Given this list of marker genes ANXA2, RHOU, PBRM1, AVL9, POLR2D, TESC, GLRX5, TMEM60, BUD23, VSNL1, TMEM200A, COL5A2, NEDD4L, DCAF4, SAMD9, ANKIB1, LYPD1, NXN, GPSM2, BHLHE41, MT1H, GSPT2, ATP5F1E, USP42, BOD1L1, TXNRD1, SUPT16H, PTPN21, MZT2B, NDUFB7, ABCB4, RPL6, MAML1, COQ5, WDR36, RGS17, NECTIN3, GATA2, MLLT3, FAM111A (FAM111 trypsin like peptidase A), CAVIN1, EEF1G, TNFAIP3, ACOXL, PNPT1, EHD3, PIN4, BAZ2B, TNFRSF9 (NCBI Gene Id 3604), BLVRA, PTCHD1, GMFB, SLC7A3, SPINK1, MARK3, VAMP1, LRRC75A, PLA2G3, PCDH20, BMP2, NCOR1, BAG5, TMEM87B, TTPAL, MYOF, NFE2L2, FGF13, BASP1, KRT34, RNF181, RIF1, PPP4R3A (protein phosphatase 4 regulatory subunit 3A), CYCS, PSMB3, ACVR1C, HNMT, CACNA2D2, BUB1, FUNDC2, MOAP1, ANXA2P3, TARS3, LRRN1, GHR, PRRX1, MC4R, MRPS24, IGF2BP3, ORMDL3, ABHD16B, FZD1, ANLN, ZFP62, EEF1B2, HEXIM1, COA3, TRIP12, CRK, ATP5F1A, PGR, VBP1, ZNF839 (NCBI Gene Id 55778), TPST1, MED6, FKBP14, DDX24, DHX8, CHCHD1, PIP5K1A, AAK1, SNX8 (sorting nexin 8), AGPS, VAMP7, NEK9, PAPSS2, SNAI2 (NCBI Gene Id 6591), MTERF1, PSME4, TMSB15B, LINC00460, FOXG1, HJURP (Holliday junction recognition protein), CDH7, MRPL44, TLE4, DUSP1, DDHD1, SRA1, APOBEC3B, UBE2C, SEPTIN7, CNOT6, RFC2, ACADL, LHFPL2, IFITM2, ELP5, DHRS2, PCDHB14, ZNF142, AMPH, TMEM200C, RACK1, FN1, UBE2QL1, GLI3, RALA, PAPOLA, CXCL8, COPS9, SSR4, AKR1C1, TSPAN7, MIS18BP1 (NCBI Gene Id 55320), NDUFA3 (NADH:ubiquinone oxidoreductase subunit A3), SAMD5, NRDE2, ADAMTS5, KCNK2, TOP1, ACTR10, SGO2, KIF18B, S1PR3, ZCCHC12 (NCBI Gene Id 257051), SLC27A6 (solute carrier family 27 member 6), ARPC2, ZNF544, CNRIP1, PSME2, PKP4, IFT57, TTLL4, BABAM1, GCC2, ZBED10P, UPP1, FSCN1, DNER, CA5BP1, ADAMTS1, YAE1, ID2, EDNRB, DBF4, NCAPH, CLASP1, TPPP (tubulin polymerization promoting protein), CCNB1, EGFLAM, SRSF1, GNG11, SYTL5, MRPL32, GPNMB, ADNP, TSLP (NCBI Gene Id 85480), here is a description of the gene set: Human Gene Set: GSE45365_CD8A_DC_VS_CD11B_DC_UP Genes up-regulated in dendritic cells: CD8A versus ITGAM+. Murine Cytomegalovirus (MCMV) infection leads to early activation of various immune cells, including B and T lymphocytes, before the actual initiation of antigen-specific adaptive immunity. This activation is partly driven by innate cytokines, including type I interferon (IFN), which are induced early after infection. The objective of this study was to address the role of type I IFN in shaping early/innate B and T cell responses to a primary acute viral infection. In order to decipher the specific impact of IFN-I on cell subsets, we performed a genome-wide expression analysis on WT splenic B and CD8 T lymphocytes isolated from C57BL/6 mixed bone marrow chimera mice. This study complements series GSE39555, which focused on early responses of NK cells and of the two subsets of conventional dendritic cells. species: Homo sapiens